Given this list of marker genes ACOT7, EGR1, MRTO4, LAMA5 (NCBI Gene Id 3911), GATD3 (NCBI Gene Id 8210), VGLL4, EIF3I, UBXN8, MLH1, SPA17, SNRPD2, NGDN, TERF1, CTPS1, CMAS, COIL, BIRC5, SMARCC1, PTTG1 (PTTG1 regulator of sister chromatid separation, securin), UBA2, MRTFB, CCT6A, PSMB6, COX11, NFRKB, CPNE1, CNPY2, MMD, CAD, FERRY3, TNFRSF10D, ZFTA, EHD3, PRMT5, PLEKHO1, RBM3, PSMD7, SETMAR, MAB21L1, RIBC2, DHRS3, CDC45, PCBP3, PALLD, CLIC4, FASLG, NR2C1, PUS3, MDFIC, DDRGK1, XPO1, DPH2, HTATSF1, HADH, MYH10, PERP, NEK4, PSMA6, LSM6, LDHA, CCT2, MFHAS1, MCUR1, ACTR1B, MRPS27, MRPL4, TUBB, ENO1, EBP, MAPKAP1 (MAPK associated protein 1), NCAPG, RPIA, TSR3, ADAM20, MAGOH2P, DNAJC16, ICAM1, RXYLT1, MANF, CIZ1, MT2A, RNF123, RPS4X, NDUFA9, PHB1, CALML4, CBS, IL15RA, MRPS12, LMAN1, TMEM177, PUS7, KIF18B, RPA3, NUSAP1, PEA15, MDH1, CCT4, SLC26A6, KIF20B, TMEM214, SMC3, PPP2CB, MPHOSPH9, PFAS, INTS11, DPP4, OBI1, GOT1, HSPA8, ACTL6A, PDE12, NDUFA8, ZW10, TBC1D16, XPO7, IL27RA, LBHD1, CTSH, CAVIN3, CTNNA1, NDUFS2, SRSF8, DLG1, TTC27, FBL, AUNIP, TBC1D4, POU2AF1, RAN, DCK, FDX1, GPSM2, ZDHHC14, MFSD13A, DNAJC10, APOLD1, PEPD, TPD52, MTX2, TOMM40 (NCBI Gene Id 10452), PIBF1, CZIB, P4HTM (NCBI Gene Id 54681), PA2G4, POLR2D, BAD, DNPH1, DNMT1 (NCBI Gene Id 1786), FOLR2, NUP205, EXOSC8, MAP4K2, SYNE3, SQLE, FANCG, CETN3, DHPS, LTA4H, RPS6KA4 (NCBI Gene Id 8986), AHSA1, NFU1, PDLIM5, LUC7L2, IMMT, VANGL1, ELAVL1, RUVBL1, TAF1B, OPTN, SEMA4C, FAT2, LSM4, ZFYVE21, MINPP1, HGH1, ATP6V0E2, APOBEC3B, PWP1, PRRC1, UBE2G2, CDKN3, CEP76, PDHX (pyruvate dehydrogenase complex component X), CSE1L, AAMP, CCNA2, CUL4A, LAIR2, UTP11, RANGAP1, PLK1, CBFB, NUP37, SCD, LSM7, TXNDC15, PSMB2, here is a description of the gene set: Human Gene Set: GSE3982_EOSINOPHIL_VS_TH2_DN Genes down-regulated in comparison of eosinophils versus Th2 cells. from publication Jeffrey KL, Brummer T, Rolph MS, Liu SM, Callejas NA, Grumont RJ, Gillieron C, Mackay F, Grey S, Camps M, Rommel C, Gerondakis SD, Mackay CR (PMID 16474395) In the present study we used Affymetrix oligonucleotide microarrays to produce gene transcription profiles for the major leukocyte types in humans. This comprehensive dataset enabled us to not only establish which genes were expressed in each leukocyte type, but also which genes were expressed in each subset after activation. The used of a comprehensive dataset of gene profiles from all the major human leukocyte subsets enabled a novel and powerful means for identification of genes associated with single leukocyte subsets, or different immune paradigms. studied in species Homo sapiens